Given this list of marker genes VAMP7, CCDC141, CRPPA, SOX2, TOGARAM1, HNRNPR, WDR11, UBE2A, POLE, ATRX, HSD3B2, RNASEH2B, MBD5, PMM2, DNHD1, TRPM3, PIGA, FANCD2, PEX6, LHX4, BRCC3 (NCBI Gene Id 79184), FKRP, LHB, FIG4, GNRH1, MOGS, SLC25A24, GPC4, NEUROD2, SGPL1, GMNN, RNF113A, SAMHD1, MAB21L1, LMX1B, ARCN1, POMGNT2, MEGF8 (multiple EGF like domains 8), PRKDC, CDC6, KIAA0586, NPAP1, BBS4, DACT1, RAC3, ECE1, NDN, MYT1L, SPEN, RNF212, POLA1, WNT7A, OGT, VPS35L, TEX15, CHRM3, ALX4, LIMK1, KISS1, GNAO1, SLC25A22, DMXL2, ARL6, TCF4, FGFR1, MOV10L1, ERCC4, NR5A1, NDUFB11, ISL1, FEZF1, HSPG2, ORC6, HS6ST1, ALG12, VPS37D, STXBP1, PNKP, SIX3 (NCBI Gene Id 6496), RAB23, PEX1, CPE, IRF6, LARGE1, SALL1, DHCR7, XRCC2, ADAT3, POMK, GMPPB, XPC (XPC complex subunit, DNA damage recognition and repair factor), DUSP6, POU1F1, KLHL10, SMC1A, DHODH (NCBI Gene Id 1723), PRDM13, NXN, TDRD9, STX1A, LMNB2, SUZ12, XPA, CCDC34 (NCBI Gene Id 91057), SMO, PSMC1, EBF3, BBS7, ESR2, POLR1D, FAM111A, RAB18, ACTB, OCA2, MCTP2, PDPN, CLIP2, RNU4ATAC, TAF4B, FKTN, GPR161, TAC3, SIL1, ATP6V1E1, MKRN3, KMT2D, NECTIN1, SETBP1, FSHB, GAD1, SRRM2, HESX1, AR, STAG3, FREM2, PHGDH, GTF2IRD2, POR, BLTP1, SLC30A7, PROP1, MYH3, PNLDC1, RFC2, HID1, ZEB2, DVL1, GAS1, MSH5, SLC29A3, SRY, TBC1D20, SOX9, DDX6, CDH2, POLR1B, HCCS, RSPO2, LEP, MTM1, KLHL41, SCN2A, CTCF, COG5, BBS1, RBMY1A1, PLAG1, SATB2, TEX14, KIF7 (NCBI Gene Id 46), TMEM270 (NCBI Gene Id 135886), CUL4B, INPP5E, SMC3, WDPCP, FANCL, DDB2, ANK1, MEG3, FANCF, CYP11B1, CEP41, TTC8, LSM11, METTL27 (NCBI Gene Id 155368), FGF8, FARSB, TBX4, GRM7, WASHC5, ALOX12B, TCTN3, GNRHR, RNU7-1, GBA2, ARNT2, HOXA13, SMARCA2, KATNIP, NANOS1, CUL7, NCF1, UBA1, FGF17, SIK1, DNA2, CYB5A, DAZ4, NSD1, KCNAB2, PRRX1 (NCBI Gene Id 5396), ARX, DNAH10, RPL10L, ARMC9, BBS5, SOX10, SPRY4, SUFU, TRIM32, ATP6V1A, WT1, WWOX, SHH, USP7, PBX1, RSPO1 (R-spondin 1), SYCP3, COL4A1, CTU2, PROK2, USP9Y, RAD51C, NHLH2, NODAL, SNORD115-1, DPM1 (dolichyl-phosphate mannosyltransferase subunit 1, catalytic), SAMD9, MID1, PPP2R3C, TP63, HERC2, POMT2, FRAS1, PROKR2, CEP290, HERC1, IFT27, TRRAP, KCNJ6, GTF2I, RFX7, ROR2, SLC39A4, TERB1, RTTN, PRKCZ, KISS1R, INTU, VAC14, ERCC6, FLRT3, BMP4, SIN3A, SMAD4, MADD, YWHAE, CASK, TCF12 (transcription factor 12), IGF2, EZH2, HMGA2, CYP11A1, SC5D, STAG1, TSPYL1, NEB, BBS9, LAMA5, TREX1, BBS10, MLXIPL, HUWE1, CT55, SCLT1 (sodium channel and clathrin linker 1), ANOS1, ELN, XRCC4, PWAR1, GABRD, ERCC8, GLI2, KDM5C, NDNF, ZMYND15, CDON, DPYSL5, RXYLT1, MBTPS2, KDM6A, ZFPM2, CCNQ, POC1A, PTCH1, DLL1, FBN1, ACTA1, UBE3B, DDX3Y, NEK1, IFIH1, COLEC10, EIF2S3, B3GLCT, MKKS, ORC4, CRIPTO, HDAC8, MAPRE2, EIF4H, DKC1, NSMF, THOC2, AXL, HOXD13, GTF2IRD1, NPHP1, TAPT1, LMOD3, SPAG17, PIEZO2, WNT5A, DAZ2, LEPR, LHCGR, MAGEL2, TAF6, FOXA2, IER3IP1, ERCC2, DCAF17, DNAJC19, DCX, MCM8, CDC42BPB, FMR1, SKI, ROBO1, CTDP1, EHMT1, GRIA3, TGIF1, KLHL40, RYR1, GRIP1, PORCN, ATAD3A (ATPase family AAA domain containing 3A), DYNC2H1, PIGP, TWIST2, FGFR2, POGZ, CDH11, PNPLA6, MED12, SLC32A1, DVL3, DHX37, CDT1, ERCC5, POMT1, DAZ1, TBX3, LZTFL1, ALKBH8, DTYMK, EXT2, DHDDS, TYMS, ALMS1, FZD2, STT3B, RIPK4 (NCBI Gene Id 54101), DYRK1A, H4C9, COX7B, IL17RD, ECEL1, WNT3, MYRF, ORC1, SEMA3A, MKS1 (NCBI Gene Id 54903), RERE, RAB3GAP2, TERB2, KAT6B, IFT172, C2CD3, CHRNG, GPC3, TCOF1, GLYCTK, POLR1C, SCAPER, CDKN1C, TBCE, CDKL5, CAMK2A, BBS2, BUB1B, CASZ1, PHF21A, LIG4, B4GAT1, BBIP1, NIPBL, PSMD12, GHR (growth hormone receptor), SDCCAG8, BUD23, B9D2, FXR1, RAB3GAP1, UBE4B, THOC6 (THO complex subunit 6), OPHN1, OTX2, SRD5A2, MAMLD1, TOE1, FANCM, PIGQ, PTPN11, ZPR1, TACR3, UBR1, ERCC3, BRD4, PPP1R12A, CENPT, PHF6, KLF1, CHD7, ZIC2, RTL1, BBS12, DNAJC30, LSS, KCNA1, CEP19, NAA10, CCDC22, DAZ3 (deleted in azoospermia 3), OTUD5, PQBP1, RPL10, B3GALNT2, DCC, ALOXE3, CFTR, PTDSS1, CHD4 (chromodomain helicase DNA binding protein 4), TRIM8, GRIN1, SHOC1, FILIP1, RAD21, KLHL15, FANCB, DAG1, ZMPSTE24 (zinc metallopeptidase STE24), BAZ1B, UBR7, DPM2, TSPY1, SOHLH1, FAT4, SRA1, RNASEH2C, TMEM216, DYNC2I1, CDC45, CCDC28B, FKBP6, DIS3L2, SYCE1, CATIP, IFT74, FBXO43, TBL2, CEP112, FOXH1, MINPP1, TUBB, POMGNT1, PAFAH1B1, SOX3, MMP23B, NR0B1, WDR35, SMCHD1, SCN1B, MEIOB, RLIM, SIX6, IFT80, GH1, MAP3K7, TEX11, STT3A, GLI3, SEMA3E, DLK1, GNB2, AHDC1, ARID1B, DISP1, KIAA0753, SPTBN1, ADAR, DYNC2I2, PDHA2, TBL1XR1, SIM1 (SIM bHLH transcription factor 1), CFAP418, LUZP1, SNORD116-1, LMNA, GATA4, PRDM16, SNRPN (NCBI Gene Id 6638), CILK1, PHF8, RNASEH2A, PWRN1, CYP17A1 (cytochrome P450 family 17 subfamily A member 1), MAP3K1, here is a description of the gene set: External genital hypoplasia Underdevelopment of part or all of the external reproductive organs. Human Gene Set: HP_EXTERNAL_GENITAL_HYPOPLASIA species: Homo sapiens